The following is a description of a gene set: Human Gene Set: GOBP_HYPOTHALAMUS_DEVELOPMENT The progression of the hypothalamus region of the forebrain, from its initial formation to its mature state. studied in species Homo sapiens, and this is the list of marker genes: PRDM13, HAP1, PLXNA3, RAB3GAP1, BAX, PLXNA1, UBB, RAX, NRP1, SOX3, NRP2, SRD5A2, UQCRQ, GSX1, OTP, PROP1, SEMA3E, NHLH2, NDNF, PITX2, FOXB1, NKX2-1, NR0B1, POU3F2, CTNNB1, NKX2-6, CRH, NCOA1 (nuclear receptor coactivator 1), SRD5A1, BLOC1S6